Given this list of marker genes Coq8a, Nip7, Rad51, Lgalsl, Tcf7, Yipf1, Klf16, Fbln5, Tm4sf5 (transmembrane 4 superfamily member 5), Krtap5-2 (NCBI Gene Id 71623), Ciita, Tedc2, Gpd1, Or10ad1c, Foxl1, Atmin, Actr3 (NCBI Gene Id 74117), Dab1, Ess2, Reep1, Cntnap1, Rin2, Smarcd1, Kcns3, Brwd1, Nkiras2, Sdc3, Gskip, Wapl, Garin5a, Mbtd1, Lctl, Phlpp1, Aplp2 (NCBI Gene Id 11804), Mob1b, Itga3, Gm57852, Wipf3, Mtmr4, Sash3, Cnih2, Ahcyl2 (S-adenosylhomocysteine hydrolase-like 2), Ralbp1, Ddx46, Morn4, Erfe, B3galt2, Dbndd2 (NCBI Gene Id 99295), Slamf9, Kcnc2, Ccnjl, Mtmr3, Lman1, Ptbp1, Slc25a51, here is a description of the gene set: from publication Chen Y, Wang X (PMID 31504780) Mouse Gene Set: MIR_6918_3P species: Mus musculus Genes predicted to be targets of miRBase v22 microRNA mmu_miR_6918_3p in miRDB v6.0 with MirTarget v4 prediction scores > 80 (high confidence targets).